Given this list of marker genes Snw1 (NCBI Gene Id 66354), Tgif1, Calr, Dhrs3, Klf2, Cnot1, Akr1c18, Asxl1, Ezh2 (NCBI Gene Id 14056), Nr2c1, Cyp26b1, Ctbp2, Aldh1a3, Zfp536, here is a description of the gene set: Any process that modulates the frequency, rate or extent of retinoic acid receptor signaling pathway activity. studied in species Mus musculus Mouse Gene Set: GOBP_REGULATION_OF_RETINOIC_ACID_RECEPTOR_SIGNALING_PATHWAY